The following is a description of a gene set: Mouse Gene Set: NUCKS1_TARGET_GENES Genes containing one or more binding sites for (Nucks1) in their promoter regions (TSS -1000,+100 bp) as identified by GTRD version 20.06 ChIP-seq harmonization. from publication Yevshin I, Sharipov R, Kolmykov S, Kondrakhin Y, Kolpakov F (PMID 30445619) species: Mus musculus, and this is the list of marker genes: Cln8, Fam110a, Slc35d1 (solute carrier family 35 (UDP-glucuronic acid/UDP-N-acetylgalactosamine dual transporter), member D1), Josd2, Bag3, Cmip, Mrm1 (mitochondrial rRNA methyltransferase 1), Gm15706, Zbtb7a, Pgghg, Kdm2b (NCBI Gene Id 30841, lysine (K)-specific demethylase 2B), Plcb3, Fbxl14, Mrpl18, Zfp809, H2-T23, Pih1d2, Ciart, Mogs, Psph, Klc2, Zbtb22, Ccdc86, Egr1, Rnf11, Rsl24d1, Ezr, 4732491K20Rik, Cep19, Scrib, Cdk19os, Lta4h, Phf5a, Nadk, Dixdc1, Slc16a11, Atpaf2, Tut7, Pik3c2b, Naa60, Gm2449, Tet2, Sav1, Elovl2, Itsn2, Tmem270 (transmembrane protein 270), Mettl21a, Zbtb46, Cpeb2, Nelfb, Sall1 (spalt like transcription factor 1), Sprtn, Zfp407, Rab40c, Cfap298, Dnm3, Naa80, Dimt1, Xaf1, Atp5po, Arnt, Baz1b, Nectin2, Prkcd, Catsper2, Eif2b3, Zfp963, Pdk2, Gm16794, Gfra1, Gm2164, Ino80b, Rhbdd3, C630004L07Rik, Cd83, Cd59a, Svil, Cspp1 (NCBI Gene Id 72327), Cdk20, Gpi1, Atg4b, Fhod3, Arl2 (NCBI Gene Id 80563), Fhip2a, Meis1, Cntln, Luc7l, Rnf123, Kpna2, Epas1, Mir5620, Cox4i1, Fam162a, Cpsf6, Mir210, Sf3b1, Rfxap, Cux1, Gps1, Enho, Crbn, Slc49a4, Arid4a, Tor1aip1, Map1lc3a, Lbr, Pigx (phosphatidylinositol glycan anchor biosynthesis, class X), Notch2, Usp5, Afg2a, Safb, Kars1, Mir219c, Ppp1r9b, Azin2, Spop, Cox17, Gm5464, Plekha1, Stk11, Ggh (NCBI Gene Id 667301), Tmem65, Lysmd3, Gm10658, Nsun2 (NOL1/NOP2/Sun domain family member 2), Grpel2, Itprid2, Nuak2, Hsd17b4, Scaf4, Gm12498, Safb2 (NCBI Gene Id 433127), H2-DMa, Hmgb1, Hsph1, Ints12, Gm4285, Sirt4, Dnajb2, C030037D09Rik, Lamtor2, Brd3, Qrich1, Mgat1, Avl9, Pank1, Bmp7, Csnk2a1, Ppp1cb, Acot9, Psme1 (NCBI Gene Id 19186), Dcun1d2, Dennd1a, Ccdc6, Mir5100, Gmfg, Ubtf, Rpl14, Cenpv, Oxsr1 (NCBI Gene Id 72172), Trim14, Eif4e, Rchy1, Pxk, Gba2, Alg9, Wdr20, Commd5, Usp18, Mettl25b, Plcg1, Tet3, Pold4, Ola1, Ifitm2, Cuedc1, Ccng2, 3110056K07Rik, Zfyve1, Arpc4, Usp6nl, Gatad1, Blm, Trappc8, Pds5b, Stk19, Rogdi, Sypl1, Scaf11, Tm7sf3, Lpar2, Spen, Prrg4 (NCBI Gene Id 228413), Chek2, Larp1b, Shroom3, Gm13375, Zfand5, Ccdc43, Atosb, Rnf170, Gm16208, Clpp, Ccdc157, Ppp4r2, Dhx33, Higd1a, Fam114a1, Mroh1, 4833445I07Rik (RIKEN cDNA 4833445I07 gene), 2810025M15Rik, Dennd5b, Ube2ql1, Cdt1, Pms2, Lpcat4, Nipal3 (NIPA-like domain containing 3), Erap1, Cebpa, Lrrc75a, Cep97, Tubg1, Lrrc46, Klhl11, Hs1bp3, Paox, Zbtb21, Gpatch2, Mrpl10, Rtp3, Hipk2, Irak2, Pik3ap1, Ankhd1, Arf2, Gm24793, Rara, Gatad2a, St3gal4, Spata17, Trim47, Dot1l, Gm27011, Foxred1, Zc3h7a, Cep76, Pigz, Azin1 (antizyme inhibitor 1), Ccdc18, Tsku, Usp8, Mcrip1, Serf1, Rassf1, Wdr53, Lims2, Mad1l1, Agpat2, Osgin1, Tsc22d2, Gm28050, Fem1c, Nup205, Phc2, Sox6os, Zfp623, Mir7666, Agpat3, Gm15564, Prdm15, Rnf220, 1700041G16Rik, Noc3l, H2-K2, Upf2, Asb1, Cep170, Tpcn1, Smad3, Galt, Polr3g, Ciao2a, Rexo4, Dus1l, Lyn, Nsun4, Gm16731 (predicted gene, 16731), Gm1401, Tsn, Fam171a2 (family with sequence similarity 171, member A2), Flii, Ercc4, Ndrg1, Myef2, Agap3, Dst, Wars2, Sf3a1, Rtkn, Lrch3, Cep85l, Utp15, Pip5k1c, Pgap2, 4921531C22Rik, Gosr2, Nfatc4, Ago1, Echdc1, Cul4b, Tmem184b, Ets2, Ppp2r2d, C130036L24Rik, Ptger4, Slc7a2, Hdgf, Wdpcp, Snord43, Dhrs4, Slc49a3, Ska3, Nfil3, Tmem135, Arf3, Ptk2, Lctl, Ndufv3, Dusp23, Erp44, Aasdh, Taok2, Cpsf4, Ap2m1, Smim26, Decr1, Btrc (beta-transducin repeat containing protein), Myo6, Ncoa2, Gm26511, Gm11973, Itga1, Irf1, Slc50a1, Fdx2, Ap1s1, Ccna2, Gramd4, Dzip3, Mpv17l2, Bltp3a, Nemp1, Nsun6, Gm22489, Sinhcaf, Mast1, L3mbtl3, Mrpl57 (mitochondrial ribosomal protein L57), Cops7a, Man2a1, Plekha5, Galnt4, Ice2, Rbis, Tmem263, Nacc1, Rab12, Reep6, Exoc4, Cited4 (NCBI Gene Id 56222), Rif1, Tmbim4, Mylk, Cdkl2, Dip2a, Oxct1as, Ccdc159, Map3k1, Isoc1 (NCBI Gene Id 66307), Thrap3, Ppp1ca, Vps26c, Kalrn, Plec, Nrip1, Pxmp2, Sil1 (SIL1 nucleotide exchange factor), Ncoa3, Wdr74, Nmd3 (NMD3 ribosome export adaptor), Mir760, Irf8, Kdm5a, Psmd11, Cacybp, Cdk10 (NCBI Gene Id 234854), Zmym1, Zfp523, 9530052E02Rik, Taf1c, Plxnb1, Ang, Lcn2, Gnaq, Zbtb14, Rasal2, Sfr1, Tmed1, Gm26224 (predicted gene, 26224), Yipf6, Clasrp, Kras, Rcor1, Gemin7, Mtfr1, Nfatc2ip, Rusc1, Pdgfc, Adnp, Chaf1b, Dhx35, Gm26728, Ergic1, Coq8a, Ric1, Furin, 1190005I06Rik, Slc25a19, Dnajb14, 1810059C17Rik, Sptlc2, Tgif1, Kcnh1, Capzb, Reps1, Fam234a, 4930481B07Rik, Phykpl, Bco2 (NCBI Gene Id 170752), Cyp20a1, Selenoh, Fgfr3, Sco1, Retreg3 (reticulophagy regulator family member 3), Slc19a1, Amigo2, Mtmr2, Ss18l1, Epo, Tmem184a, Pdpk1, Osbp, Sos2, Gm10138 (NCBI Gene Id 108167733), 1700041I07Rik, 1700008J07Rik, Arhgap39, Ttc4, Dhcr7, 4930405A21Rik, Zcwpw2, Gm15541 (NCBI Gene Id 105242887), Atp6v1c1, Qki, Tsr1, Ptgr3, Gm22935, Poln, Stard5, Ddx46, Polr2k, Hpf1, Cdkn2a, Armc6, Thrb, Cip2a, Dusp14, AA467197, Nt5c, Fzd9, Nsmf, Scnn1g, Zdhhc17, Nup98, Gfap, Pex11g, Sec62, Gm13999, Prkca, Ccdc96, Dpysl2, Tpt1 (NCBI Gene Id 22070), Xylt2, Neurl1a, Klf16, Cyb561, Cmss1, Chmp3, Phf7, Uhrf1, Uqcc6, Gm27021, Trappc2l, Slc9a5, Dcp1a, Mir132, Ncl, Nktr, Sphk2, Tnk2, Fign, Gm10472, Eif4g1, Rundc3a, Grk2, Psme4, Wdr4, Cnot8, Ivns1abp, Tha1, Gm9967, Zdhhc7, Inka1, Cln5, Ifnar1, Adam9 (ADAM metallopeptidase domain 9), Tmem241, Mir212, Arap2, Ppl, Mblac2, Samd1, Rnf187, Syne2, Gm26881, Nkiras2, Pwwp3a, Zfp248, Zfp26, 4933406C10Rik, Tmem205, Dock5, Prkce, Actr6, Ypel1, Dlgap4, Zfp280d, Sh2b3, Slc17a8 (NCBI Gene Id 216227), B3galt1, Rgp1, Pbx3, Lztr1, Epm2a (NCBI Gene Id 380675), Ddx55, Supt3, Gm34086, Hlcs, Ahr, D630045J12Rik (NCBI Gene Id 330286), Sgsm2, Gm10516, Mus81, Lmtk2, Hp1bp3, Tmbim6, Slc4a2, Lsm1, Galk2, Cct6a, Rhbdf2, Rdh5, Agap1, Kdm3a, Zfp800, Nop58, Gm12101, Hdhd5, Plekha8, Syndig1l, Zftraf1, Mt2, Magohb, Trim27 (tripartite motif-containing 27), Dop1b, Mpzl1, Ring1, Rps10, Yme1l1, Yap1, Ppp1r13b, Kank2, Usp33, Gm7008 (NCBI Gene Id 638458), Zfp687, Med20, Mcfd2, Washc1, Nr3c1, Mtfmt, Utp14b, Gm9917, Lexis1, Apip, Gm9955, Eps15l1, Lats2, Cep152, Mfsd12, Scaf1, 6330562C20Rik, Ubash3b, Scly, Sh3yl1 (Sh3 domain YSC-like 1), Hsp90ab1, Casd1, Apmap, Chic2, Dock1, Cep83os, Fbxw7, Dnai1, Dnase2a, Nek9, Borcs5, Mbd3, Eeig2, Isg20, Smo, Amdhd1 (amidohydrolase domain containing 1), Atp5f1a, Rbm38, Ptcd1, Usp21, Bloc1s6, Mrpl37, Relt, 2810402E24Rik, Sypl2, Gm16638, 1700112D23Rik, Birc5, 2410002F23Rik, Anapc4, Rab40b, Mir1938 (NCBI Gene Id 100316693), 4930581F22Rik, Map2k7, Etv5, Fhod1, Peds1, Spata6l, Sec24a, Fxr1, Aco1, A430005L14Rik, Pole (NCBI Gene Id 18973), Psd3, Cecr2 (CECR2, histone acetyl-lysine reader), Galns, Cog6, Esrra, Drg1, Ap2s1, Srd5a1, Pdlim2, U2af2, Mrfap1, Cars2, Brpf3 (bromodomain and PHD finger containing, 3), Ubr5, Srsf10, Gm14320, Dhx9, Arl5b, Septin11 (septin 11), 2010109A12Rik, Cfap418, Tmed5, Pcbd1, Man1a2, Tnks2, Sh2d4a, Mir5627, Vmac, Edar, Shfl, Scn1b, Kbtbd13, Fkbp1a, Psmc3ip, 9330162012Rik, Mtfr2, Slc5a3, Bcar3, Hap1, Rarres1, Zfp62, Gng7, Rpp25l, Snx24, Dapk3, Appl2, Tpd52, Samd4, Hpn, Tatdn3, Tigd2, Scrn2, Rint1, Ecpas, Zdhhc5, Ppp6r1, Myc, Ogfrl1, Gm10785, Mapre1, Pdcd4, Pgm2, Aldh9a1, Grk5, Smarce1, Bach2, Oxct1, Osgin2, Cbx1, Slc30a9, Tsen34, Shld2, Tmed9, Gm15663, Vamp4, Rdm1, Gdi2, Mknk2, Slc39a6, Erlin2, Usp34, Atf6b, Trp53rka, Stim2, Snora7a, 1110002L01Rik, Aebp2, Usp4, Nfkbil1, Ggnbp2, Gm22107, Mix23, Axin2, Cdc42bpg, 2610005L07Rik, Srm, 1500015A07Rik, Etaa1os, Klhl22, Rab3gap1, Aftph, Rragd, Myl12a, Arl1, Pspc1, Tcp1, Hnrnpa0, Pold1, Gfer, Neurl4, Msh5, Ntaq1, Hscb, Supt16, Zfp574, Tle1, Gm10322, Mtmr10, Sergef, Mkln1os, Pgm2l1, Polr3d, Agbl3, Dusp3, Syt3, Arhgap29, Gng10, Polr2b, Uspl1, Fhl4, Tdp1, Pfkfb2, Ptgr2, Gnb2, Dnal4, Pard6a, Plpp2, Prkab1, Hyal2, Cbx2, A130014A01Rik, Sgms1, R3hdm4, Rabep2, Pop5, Atosa, Cfap97 (NCBI Gene Id 66756), Tardbp, Dbt, Prex1, Sanbr, Coq10b, Gmeb1, Hdac5, A330023F24Rik, Amz2, Srp68, Bend7, Rictor, Trnau1ap, Atp2a2 (ATPase, Ca++ transporting, cardiac muscle, slow twitch 2), Tmem51, Atxn7l1, Trf, Pals1, Snx9, Dsg2, Dipk2a, Snupn, Arl16, Acacb, Trmt1, Rps2, Fut8, Mmp17, Iqank1, Abcd4, Rab22a, Mboat7, R3hdm2, Mettl27, Lpcat3, Ano6, Azi2, H6pd, Chn2 (chimerin 2), Fam227b, Pi4kb, Mrm3, Zc3h4, Colec12, BC001981, Rnf13, Ccdc38, Sfmbt1, Slc12a6, Dock7, Ube2k, Zfp703, Cystm1, Sec11c, Plagl2, Mrpl15, Pde4d, Mtx3, Cfl1, Zcchc17, Gxylt1, Ppp4r1l-ps, Casc3, Cirbp, S100a16, Fpgs, Unc13a, Otub1, Rev1 (NCBI Gene Id 98573), Wdsub1, Gosr1, Zfp217, Epb41, Rps5, Nub1, Rpn2, Gas5, Gm29707, Metap1d (methionyl aminopeptidase type 1D (mitochondrial)), Mfsd5, Ago2, 2300009A05Rik, Ankrd13b, Dhrs7, Mak, Senp6, Zbtb25, Prdm10, St6galnac6, Diaph2, Slc17a5, Vps13a, Gm9530, Ubl5, Fam83h, Fgf20, Fosl2, E230029C05Rik, Stub1, Cfap210, Gm57857, Stxbp3, Ulk1 (NCBI Gene Id 22241), Egln1, Atn1, Ptp4a2, Dcaf11, Arhgap21, Aldh5a1, Ndufaf3, 4930461C15Rik, Rccd1, Grcc10, Map3k5, Mob4, Bap1 (Brca1 associated protein 1), Tfrc, Tdrd7, Mindy2, Mir378a, Nuak1, Nup153, Usf2, Cpsf2, Atp5f1e (NCBI Gene Id 99243), Kctd6, St3gal5, Lrba, Fbxo34, Rplp0, Gucd1, Srpra, Skic2 (NCBI Gene Id 57807), Mir6236, Zfp786, Slc39a7, Mroh8, Efcab11 (NCBI Gene Id 78767), Zfp455, Rnf141, Rab4a, Ranbp2, Cish, Dennd6a, Msx1, Letm2, Kiss1r, Gm43403, Fbxo3 (NCBI Gene Id 98847), Rfx3, Gna11, Ipo8, Thap6, Rap1gds1, Brpf1, Slmap, Zfp597, Cgref1, Ptges3l, Eif2ak1, Bcl2l1, Gm17494, Msl2, Smim7, Prkaca, Paip1, Sft2d2, Dut, Mm2pr, Myo18a, Stpg1, Tlcd1, Cideb, Ephx2, Dusp28, Mir7075, Nyap1, Mir5133, Mrpl12, Tmem39b, Phospho2, Cbfb, N4bp2l1 (NEDD4 binding protein 2-like 1), Cep44, Hspbap1, Ccdc137, Junos, Alg2, Ppm1g (NCBI Gene Id 14208), Ier5l, Fam193a, Mmgt2, Rprd2, Rhbdl1, Vkorc1l1, Dcaf5, Syt12, Ythdf3, Gm16230, Acap2, 9930014A18Rik (RIKEN cDNA 9930014A18 gene), Prkar2a, Agtpbp1, Fgd4, Slc25a25, P2rx5, Cdc42, Camta1, Nfic, Hpcal1, Ak2, Gm2788, Rev3l (NCBI Gene Id 19714), Sacm1l, Mitf, Kdelr2, Zscan2, Scarb2, Armc7, Rpl22, Sigmar1, Ralgds, Slc25a45, Asxl2, Cyp4f13, Cldn14, Gm16845, Dtwd1, AA474408, Elp2, Atp6v0e, Vamp3, Gm13687, Camk2d, Ndufa11, 2900089D17Rik, Ssbp1, Fam72a, Pou6f1, Gdf9, Mov10, Mir8101, Cep250, Xrn1, Anapc5, Serpinf2, Snx30, Mafa, Ccdc32, Dctn6, Gm20716, H2az1 (NCBI Gene Id 51788), Cep83, Taf10, Ubp1, Socs1 (suppressor of cytokine signaling 1), Uqcrq, Ttc21b, Cyb5r1, Slc44a1, Ubr1, Mir148a, A530013C23Rik, Sugct, Osbpl1a, Ndufa5, Nhlrc1, Tcta, Tnip1, Mphosph8, Gnai3, Snx1, Snx22, Enpp4, Tmem38a, Epb41l1, Caprin2, Camk2n2, Spice1, Arhgef12, Tmem51os1, Cep170b, C130046K22Rik, Smurf2, Ilvbl, Zscan29, Ppp2r5a (NCBI Gene Id 226849), Ap4b1, 4933417C20Rik, Kif11, Irx3os, Kmt5a, F730043M19Rik, Gm9694, Usp12, Pold2, Gm22748, Cdca2, Dstyk, Lin37, Fra10ac1, Lrpprc, Ndufc1, Rab4b, Hspb8, Sec61b, Alg11, Rmc1, Bltp2, Dbndd2, Mtmr4, Tpm1, Gm10649, Nrbp1, Vav2, Clint1, Cmc1, Mgmt, Tubgcp4, Stat5a, Zdhhc2, Crlf2, Gm22357, Mesd, Uhmk1, Nsf, Shox2, Ypel3, Cpeb4, Homez, Glul, Wipi1, Snx27, 4933406P04Rik, Sbf1, Syncrip, Trim41, Grik4, Gm28707, Zfp865, Rps13 (ribosomal protein S13), Hgs, Atp7b, Lnpep, Glyctk, Elmo2, Zfhx4, Pofut1, 6720483E21Rik, Tcte2, Smim14, Unc119b, Crk, Rps6ka5, Ubr3, Efcab14 (NCBI Gene Id 230648), Gnl2, Mettl13 (NCBI Gene Id 71449), Cxcl10, Gstk1, 2310057M21Rik, A330074K22Rik, Nup107, Msh6, Nfyb, Gm2093, Ankrd27, Gclm, Pias3, Helz, Tiprl, Cby1, Set, Smad4, Nsmce4a, Lsm10, Rxrb (retinoid X receptor beta), 2900093K20Rik (NCBI Gene Id 68037), Zer1, Rpl5, Cbx4, Trip4, Zmym5, Mir7071, Sde2, A930038B10Rik, Chchd5 (coiled-coil-helix-coiled-coil-helix domain containing 5), Slc22a5, Snrpd3, Csrnp2 (cysteine-serine-rich nuclear protein 2), Tex22, Zfp423, 4930589O11Rik, 4732463B04Rik, E2f8, Sumo3, Asb15, Tmem87b, Smpd5, Fbl, Nelfe, Cep57l1, Zbtb37, Arhgef19, Paics, Orai2, Phf20l1, Brd9, Ap2a1, Tgfbr1, Ndufaf2, Tada3, Pitpnm1, Nr3c2, Mllt10, Ankrd13c, Taf4, Zbtb2, 4931422A03Rik, Dnaaf9, A930007I19Rik, Khdc4, Prr12, Bivm, Scp2, Rbpj, Plekho2, Myo1d, Blvra, Kidins220, Garem1, Kansl1, Sesn1, Chst12, Pxylp1, Cdc16, Haus3, Pdhx, Ccdc77, Caprin1, Gnb1, Glod4, Rere, Gm17552, Serpini1, D230022J07Rik, Dpy19l4, H2-Q10, Ranbp6, Pdcd10, Pafah1b1, Arhgef10l, Hgfac, Nin, Tppp3, Ptpn21, Larp4, Tmco3, 4930532G15Rik, Rfng, B230217O12Rik, Ccnyl1, Trip10, Brf1, Dtymk, Slc38a3, Trip13, Setd6, Gm40123, Rhpn2, Mplkip, Fitm2, Rpl3, Rock2, Dpy19l1, Mafk, Slc12a7, Map3k4, Terf2, Rybp, Gmds, Isoc2a, Tmem214, Eif5a, Csnk1g1, Ube2m, Ehd4, Hlf, Cav2, Gm5914, Adcy9, Hook3, Rnf44, Eif5a2, Ywhaz (NCBI Gene Id 68643), Cdkn2aip, Pcsk6, Zfp760, 1700086O06Rik, Nos1ap, Memo1, Dido1, Nedd4l, Gas2, Smyd3, Setd1a, Ghr, Cdca3 (NCBI Gene Id 80405), Ppm1d, Wdfy3, Cadps2, Gm28042, Fbxo45, Slc6a21, Icmt, Twf2, Syn3, Vegfc, Yes1, Dlat, Pcbp4, Zbtb7c, Tbc1d10c (TBC1 domain family, member 10c), Mrps18a, Ppat, Cfap36, Dnajb12, 0610010K14Rik, Cdon, Tmx4 (thioredoxin-related transmembrane protein 4), Znhit6, Rasl10a, Gstp1, Cdc42ep1, Cic, Rhoa, Acd, Ptpmt1, Adipor2, Spata13, Tfam, Mfsd3, F730035M05Rik, Ctbs, Aldh1b1, Mtch2, Plekhh3, Tatdn2, Ppdpf (NCBI Gene Id 73215), Tmem63b, Arhgef7, Nexn, Mthfsd, Gar1, Yod1, Vps45, Clip1, Msi2, 2810408I11Rik, Bloc1s6os, Pnkd, Dxo, Sh3bp5, Cep350, Car8, Adprm, Mlxip, Tmem59, Bag4, Gm21985, Fam222a, Ifnar2, Ube3a, Crebzf, Als2, Zfp113, Rundc1, Tirap, Mfsd10, Phip, Acp1, Vezf1, Mst1, Dennd10, Tsc22d4, Snrnp35, Os9, Wtap, Zfp213, Emc8, Pcsk4, Ldb1, Zbtb1, Afdn, Mkks, E130308A19Rik, Skic8, Zfp148, Pear1, Tuba1b, Pacsin2, Tmem201, Slfn9, Mgst3, Max, P2rx4, Oser1, Cnot6l (NCBI Gene Id 338514), Unc5b, Prdm2 (NCBI Gene Id 74588), Pgap1, Abhd16a, Dnajb9, Sgta, Mta2, Psmg2, Flvcr2, Prelid3b, Zfp266, Kmt2c, Ercc8, E130102H24Rik, Upf3a, Atf3, Sephs1, Gm14167, Atp6v1g2, Slc41a2, Dgcr8, C630043F03Rik, Riox2, Clip2 (NCBI Gene Id 269713), Angel2, Fam227a, Celf1 (NCBI Gene Id 98760), Dclre1b, Rtn4, Met, Tmcc3, Srsf4, Rab3d, Etohd2, Anxa11, Pcnx4, Tceanc2, Sik3, Exosc3, Iqcd, Gchfr, Ndel1, Mir7236, Mir7653, Anp32a, Trim24, Ap1ar, Pogk, Zbtb16, Specc1, 6430571L13Rik, Unc119, Klhl25, Dnajb4, 9030607J07Rik, Mmp14, Pkn3, Prpf39, Rxra, Tnfaip8l1, Bloc1s1, Pnisr, Gpr155, Snord35b, Nim1k, Ift46, Iffo2, Gm20517, Lypla1, Zfp746, Ubl7, Cop1, Nudt3, Slc43a2, Mastl, Ntpcr, Mtmr3, Sdccag8, Dpm1, Kri1, Elovl5, Acot7, Tmem259, Fbxl5, Crip2 (cysteine rich protein 2), Ufl1, D430001F17Rik, Madd, Gm12915, Srcap, Slx4ip, Nanos1, Nectin3, Jun, Fkbp9, Klhl2, Ctdspl2, Slc25a12 (NCBI Gene Id 99450), Gm15283, Fance, Polr1b, 2810408A11Rik, Nr4a2, Arrdc2, Polr3f, Spsb2, Gm4925, Rab21, Paqr8, Mpnd, Bag6, Hdac11, Zfr, Ssx2ip, Eml5, Mir8114, Rsrc1, Hnrnpd, Rbbp8, Snrnp40, Bscl2, Tef, Nfxl1, Sec31a, Aco2 (NCBI Gene Id 28130), Cfap410, Mmp15, Fam219a, Sltm, Nme1, Ogdh, Angel1, Ndufs5, Smad9, Eif3h, Ube2b, Coro1c, Mcu (NCBI Gene Id 69874), Gm2a, Crem, Rheb, Dnah17, Sgpp1, Erc1, Ccdc63, Ddx31, Jmjd7, Rgs9bp, Gm20684, Arhgef17, Rngtt, Spast, Hid1, Plrg1, Dna2, A430018G15Rik, Papolg, Gm16104, Mkln1, Derl3, Sox6, AA386476, Mrpl9, Poglut2, Mtnap1, Fstl3, Ikbke, Ascl4, 5830411K02Rik, Mex3b, Rreb1, 9430015G10Rik, Dnmt1, Pdia3, Rbm26, Xrcc2, Lrig3 (NCBI Gene Id 78922), Mapk1ip1l, Icam4, Npn2, Nsl1, Donson (downstream neighbor of SON), Glce (glucuronyl C5-epimerase), Washc4, Tent2, Itpr1, Eif4a2, Nucb1, Mocs3, Dpysl5, Mxi1, 6820431F20Rik, Atf1, Mrps6, Smndc1, Parp1, Pnpla2, Cdh2, Zeb1, Cfap68, Crnde, Fbxw8, Dusp12, Mir574, Slc35b4, Gm29642, Ppid (peptidylprolyl isomerase D (cyclophilin D)), Pdcd6, Midn, Smyd2, Zfp628, Kat6a, Gmppb, Slc15a4, Pygl (NCBI Gene Id 19308), Tm2d1, Birc2, Eps15, Gm15420 (predicted gene 15420), Ric8b, Prpf8, Gprin3, Dnaja1, Agrp (NCBI Gene Id 11604), C430014B12Rik, Fkbp5, Atp6v1a, Wdr55, Rnase4, Il7, Hebp2, Pde7b, Rnft2, Naa20, Dbnl, Vps37d, Upf1, Sertad1, Cdk4, Gm26590, Dzank1, Mir207